The following is a description of a gene set: Transforming growth factor-beta (TGFbeta)-activated signalling pathways can lead to apoptosis, growth arrest or promotion of malignant behaviour, dependent on cellular context. The molecular mechanisms involved in TGFbeta-induced apoptosis remain controversial; although changes in gene expression are thought to be pivotal to the process, several different candidate apoptotic initiators and mediators have been proposed. Smad4, a critical component of the TGFbeta-induced transcriptional machinery, is shown here to be essential for induction of apoptosis. Gene expression analysis identified the proapoptotic Bcl-2 family members, Bmf and Bim, as induced by TGFbeta, dependent on both Smad4 and p38 function and the generation of reactive oxygen species. TGFbeta-induced Bmf and Bim localize to cellular membranes implicated in apoptosis. Inhibition of the TGFbeta-induced expression of both these proteins together provides significant protection of cells from apoptosis. The TGFbeta-triggered cell death programme thus involves induction of multiple BH3-only proteins during the induction of apoptosis. from publication Ramjaun AR, Tomlinson S, Eddaoudi A, Downward J (PMID 16909112) Apoptotic genes dependent on MAPK1 and up-regulated in AML12 cells (hepatocytes) after stimulation with TGFB1. Human Gene Set: RAMJAUN_APOPTOSIS_BY_TGFB1_VIA_MAPK1_UP studied in species Mus musculus, and this is the list of marker genes: SH3GLB1, HSPA1B, TP53INP1, BCL2L11, BMF, CARD10